Given this list of marker genes AUP1, UBE2J1 (ubiquitin conjugating enzyme E2 J1), DERL1, HERPUD1, YOD1, DERL2, RHBDD1, UFD1, NPLOC4, BCAP31, AFG2B, SEC61B (NCBI Gene Id 10952), ERLEC1, SEL1L, DERL3, OS9, HSP90B1, FAF2, HM13, EDEM1, SYVN1, TMEM129, VCP, EDEM2, SVIP, UBAC2, SELENOS, BRSK2, UBE2G2, here is a description of the gene set: Human Gene Set: GOBP_ENDOPLASMIC_RETICULUM_TO_CYTOSOL_TRANSPORT The directed movement of substances from endoplasmic reticulum to cytosol. species: Homo sapiens